The following is a description of a gene set: Human Gene Set: GSE19401_PAM2CSK4_VS_RETINOIC_ACID_STIM_FOLLICULAR_DC_DN studied in species Homo sapiens from publication Suzuki K, Maruya M, Kawamoto S, Sitnik K, Kitamura H, Agace WW, Fagarasan S (PMID 20643338) Germinal centers (GCs) are clusters of activated B cells built on stromal cells known as follicular dendritic cells (FDCs). In the Peyer’s patches (PPs), GCs are chronically induced by bacteria and are the major sites for generation of gut IgA immune responses. Whether FDCs directly contribute to the IgA production in PP GCs is unknown. To investigate the role FDCs in gut immune system, we examined comprehensive gene profiles of FDCs purified from PPs or perypheral lymph nodes (pLNs) with or without immunization. We also tried to reconstitute the PP FDC signature in vitro by pulsed or continuous stimulation of pLN FDCs through TLRs, RARs or simultaneously through TLRs and RARs. Genes down-regulated in the in vitro follicular dendritic cells from peripheral lymph nodes (96h): Pam2CSK4 versus tretinoin., and this is the list of marker genes: RTF1, HMGCS2, ATP2C2, CACTIN, IGF1R, CPNE3, PPP1R13B, SCN7A, KLHL21, ACKR1 (atypical chemokine receptor 1 (Duffy blood group)), SEPHS1, REG3A, MYCBP, MTNR1B, AQP2, OCM2, OPRD1, HEXIM1, DOT1L, KLRA1P, PTH2R, FNBP1, RHBDL1, CLCN1, SRD5A1, ZER1, MEST, STON1, SH3GL2, RAB3A, DNMBP, ZNF212, DCAF8 (NCBI Gene Id 50717), CEP68, BPHL, SEC61A1, NHERF1 (NHERF family PDZ scaffold protein 1), BBC3, TECPR2, ANK3, CDH15, GOLGB1, MCAT, SUPT7L, MICAL3, CLIP3, BTD (biotinidase), HTR7P1, CYP26A1, MRC2, ZKSCAN1, CLTCL1, PDHA2, CDK3, COPS6, BRD3OS, TFAP4, SH3BP2, RHOBTB1, CASK, C8B, FGF13, RFTN1, MXI1, MXD4, GPSM2, RBM4B, HMX1, FGFR1, SSX2IP, ATRX, ELAVL1, NEDD4L, NF1, TLE3, UNC93A, EIF2AK1, SERPINF2, PIK3R4, ARB2A, EFCAB11, CCDC9, HMCES, KRT18, LPP, SH3BGR, USP5, TACR3, PAGE1, HAO1, UBE2B, GRAP, IFNA16, HSD17B8, SMAD3, IFNA5, CCL21, CMKLR2, SEC14L2, CLINT1, SCAF8 (SR-related CTD associated factor 8), KATNB1, RAB36, PPARA, SRRM2, SUN1, EPB42, OGT, DOC2B, PRR3, ZNF169, SKIC8, GNB5, CSNK1G2, MLH3, ALMS1, LUZP2, STK38, SPRY2, OR7A5, EZH1, AKAP9, SCG2 (secretogranin II), FOXO1, LSAMP, DBH, SLC25A42, CTDSPL, ARIH2, ATP2A1, LHX2, PLCB1, EPCAM, SNU13, DPYSL4, ABLIM1, PREPL, ZRSR2, NR2C1, PDE3B, BMS1, DGKG, ESRRG, ZHX3, CPLX2, CERNA1, NXPH2, ABCF2, MCAM, ERCC2, ARR3, TIMP4, CDC42EP3, UHRF2, AKT3, FGF6, TJP1, SNAPC4, TNNC2, NRG1, P2RX1, NRTN, RAB22A, HSF4, NUP155, COG2, MAL, ZNF268, CRY2, CRYAA, ALX3, ANKRD7, BRD1, GUSBP11, TULP1, STK16, CNTN1, PTGDR2, C2CD2, CHRNA6, SLC28A2, BAHD1, SPARCL1, PCDHGB4, CHP1, NCAPH2, ENTPD2, TBKBP1, SARAF, GCN1, MAP3K3, FLNC, KRT31, B4GALT6, SLC6A3, CBARP